The following is a description of a gene set: studied in species Homo sapiens Each fraction of mouse hematopoietic cells was purified by cell sorting from bone marrow of 8-week-old C57BL/6 mice, and its gene expression was analyzed. from publication Konuma T, Nakamura S, Miyagi S, Negishi M, Chiba T, Oguro H, Yuan J, Mochizuki-Kashio M, Ichikawa H, Miyoshi H, Vidal M, Iwama A (PMID 21540074) Human Gene Set: GSE27786_CD8_TCELL_VS_MONO_MAC_UP Genes up-regulated in comparison of CD8 T cells versus monocyte macrophages., and this is the list of marker genes: POLR1H, ATP5F1B, VPS16, DNAAF4, ZNF800, JMJD6, CREBRF, ATPAF1, RPS6KA3, SMARCC1, IMMP1L, NKRF, MPLKIP (M-phase specific PLK1 interacting protein), ENSG00000267882, TUBB2B, TBCEL, JPT1, SLC22A5, TOP1MT, UBA3, MAD2L1BP, ZBTB45, CELF2, HNRNPH1, DMAC1, TNFSF8, NDUFAF4, AAMDC, BABAM1, HS2ST1, GNAS, HUWE1, YIPF5, TNFRSF18, CBX6, TCHP, TOMM7, NDUFS3, STK4, IVNS1ABP, TAMALIN, C2orf76, TDRKH, ATP5MC2, ANKRD44, RNF113A, FOXK1, SUCLG2, TP53BP1, BANF1, PIK3R5, DNAJA3, PAK1IP1 (PAK1 interacting protein 1), MEF2D, SLA2, PDCD6, APLF, CCDC91, HNRNPA1, IL18R1, KDM1B, ZNF566, ZNF623, MLYCD, PPCS, CHD6, EARS2, MBNL1, RUSF1, ATF7IP, ANTKMT, NEMF, PSMG2, RWDD1, SLC44A2, CDK13, RNASEH2A, TRIM44, SPATA6, UBXN11, ZC3H14, EIF2B4, SMAD4, KCNQ1OT1, CST7, MAF1, STK17B, WTAP, PPP4R2, ABHD14A, MED1, FLNB, IGBP1, MED12, NDUFA12, NFATC2, CCDC51, NAA10, PTGES3, ACOXL, TAF8, RBMXL1, PHF20, FBXO7, GPATCH2, PDCD1, GBP7, TIMM13, FAM120B, DRG1, EXOSC10, SACS, ZBTB8OS, SUFU, SLC25A22, COX11, DVL1, ALKBH7, MRPL2, ZNF169, PFAS, KLF3, ANAPC16, ARFRP1, ARHGEF3, PRORP, IARS1, RABEP2, SHLD1, TP53INP1, IDH3B, SLC7A6, AIMP1, SFMBT2, NARS2, HOOK1, MTAP (NCBI Gene Id 8008), CTU1, SLFN13, ITGA6, JAGN1, NGLY1, ZBTB44, METTL13 (methyltransferase 13, eEF1A N-terminus and K55), UROS, TMEM70, HTATSF1, S100PBP, OSBPL5 (oxysterol binding protein like 5), ST8SIA1 (ST8 alpha-N-acetyl-neuraminide alpha-2,8-sialyltransferase 1), IGKC, CAB39L, AMACR, ZC3HAV1, HMG20A, RAPGEF1, UBE3A, ADH5, ADSL, KRT15, IRF1, GLRX5, RNF2, GNPTG, UQCC6, POU5F2, DDX24, SETD2, USP34, LMNTD2, DUS3L, AEBP2, IL21R, IPO4, EI24, KHDRBS1, SLC35G1, LCMT2, NCOR1, AFG3L2, LAPTM5, UBA1, WDR77, CAMK2B, RCCD1, ANGPTL4, MDH1, ZNRD2, PGM2L1, PSMD12, TAF3, FAM118A, NEK7, SMC4, ABCB8, PHF14, MAP2K2, IPO5, CNOT6L